Given this list of marker genes Ncoa3, Kmt2d, Fshr, Med1, Ppp5c, Srarp, Wbp2, Nr3c1, Ar, Parp1, Ntrk2, Bdnf, Foxa1, Pagr1a, Pak1, Ncoa2, Lmo3, Skp2, here is a description of the gene set: Mouse Gene Set: GOBP_POSITIVE_REGULATION_OF_INTRACELLULAR_STEROID_HORMONE_RECEPTOR_SIGNALING_PATHWAY studied in species Mus musculus Any process that activates or increases the frequency, rate or extent of the activity of any intracellular steroid hormone receptor signaling pathway.